The following is a description of a gene set: studied in species Mus musculus Somatic cells can be reprogrammed to a pluripotent state through the ectopic expression of defined transcription factors. Understanding the mechanism and kinetics of this transformation may shed light on the nature of developmental potency and suggest strategies with improved efficiency or safety. Here we report an integrative genomic analysis of reprogramming of mouse fibroblasts and B lymphocytes. Lineage-committed cells show a complex response to the ectopic expression involving induction of genes downstream of individual reprogramming factors. Fully reprogrammed cells show gene expression and epigenetic states that are highly similar to embryonic stem cells. In contrast, stable partially reprogrammed cell lines show reactivation of a distinctive subset of stem-cell-related genes, incomplete repression of lineage-specifying transcription factors, and DNA hypermethylation at pluripotency-related loci. These observations suggest that some cells may become trapped in partially reprogrammed states owing to incomplete repression of transcription factors, and that DNA de-methylation is an inefficient step in the transition to pluripotency. We demonstrate that RNA inhibition of transcription factors can facilitate reprogramming, and that treatment with DNA methyltransferase inhibitors can improve the overall efficiency of the reprogramming process. from publication Mikkelsen TS, Hanna J, Zhang X, Ku M, Wernig M, Schorderet P, Bernstein BE, Jaenisch R, Lander ES, Meissner A (PMID 18509334) Genes with high-CpG-density promoters (HCP) without H3 methylation marks at either H3K4 or H3K27 in MCV8.1 cells (induced pluripotent cells, iPS). Mouse Gene Set: MIKKELSEN_IPS_HCP_WITH_H3_UNMETHYLATED, and this is the list of marker genes: Fgf6, Krt26, Dmrtc2, Glra1, Abca14, Cnga4, Clic5, Pcdhb20, Nos1, Dnajb8, Gm5124, Grid2ip, D630003M21Rik, Rtl8a, Dpep3, Abcc9 (ATP-binding cassette, sub-family C member 9), Diras1, Sst, Lypd4, Brdt, Slitrk2, Mycs, Fscn2, Adam1b, Cyp4f39, Il12a, Pcdha8, Nt5dc2, Tnni3, Prm1, Adcyap1, Tssk2, Ccdc83, Pdha2, Tal1, Tex101, Piwil1, Edar, Pcdha6, Pcdhb19, Tektip1, Sstr2, Lrrc8e (NCBI Gene Id 97482), Spata22, Slc26a5, Nrsn1, Tex13b, Pcdhb10, Pcdhb22, Zdhhc25, Bahcc1, Spire1, Ahrr, Asz1, Tuba3b, Ftl2-ps, Sec1, Kcnd3, Pcdhb21, Xylt2, Sh3d19, Lypd2, Gigyf1, Krt27, Pla2g4e, Cryga, Pcdhb18, Pcdhb4, Kcnh6, Nap1l5, Prss44, Col8a1, Golga7b, Barhl1, Mgat4d, Scgn, Slc45a1, Dcc, Ccdc110, Marchf10, Rasgrp3, Pomc, Pcdha7, Cyp4x1, Spag8, Or8s8, Spo11, Jph2 (junctophilin 2), Iqca1l, Rcvrn, Or2f1b, Mfap2